The following is a description of a gene set: species: Homo sapiens The t(8;21)(q22;q22) occurs frequently in acute myelogenous leukaemia and gives rise to the transcription factor fusion protein, RUNX1-RUNX1T1 (also known as AML1-ETO). To identify the genes dysregulated by the aberrant transcriptional activity of RUNX1-RUNX1T1, we used microarrays to determine the effect of this mutation on gene expression in human progenitor cells and during subsequent development. Gene signatures of these developmental subsets were very dissimilar indicating that effects of RUNX1-RUNX1T1 are highly context dependent. We focused on gene changes associated with the granulocytic lineage and identified a clinically relevant subset of these by comparison with 235 leukaemia patient transcriptional signatures. We confirmed the overexpression of a number of significant genes (Sox4, IL-17BR, CD200 and gamma-catenin). Further, we show that overexpression of CD200 and gamma-catenin is also associated with the inv(16) abnormality which like RUNX1-RUNX1T1 disrupts core binding factor activity. We investigated the functional significance of CD200 and gamma-catenin overexpression in normal human progenitor cells. The effect of IL17 on growth was also assessed. Individually, none of these changes were sufficient to recapitulate the effects of RUNX1-RUNX1T1 on normal development. These data provide the most comprehensive and pertinent assessment of the effect of RUNX1-RUNX1T1 on gene expression and demonstrate the highly context-dependent effects of this fusion gene. Genes down-regulated in monocytes by RUNX1-RUNX1T1 fusion. Human Gene Set: TONKS_TARGETS_OF_RUNX1_RUNX1T1_FUSION_MONOCYTE_DN from publication Tonks A, Pearn L, Musson M, Gilkes A, Mills KI, Burnett AK, Darley RL (PMID 17898786), and this is the list of marker genes: IVNS1ABP, PTGER3, LTB, ADAMDEC1, CD1C, HBG1, PDE4A, CD1E, LDLRAD4, KAT2B, SLC38A1, HIP1, ARL4C, ADAM8, ITGB7, UGCG, PACC1, ROCK2, AP3S2, CD1B, HDC, HBA1, HBB, CCR6, SMARCA2, STK17B, SRPRA, FGL2, ENTPD1, ICAM3, RNF24, MAP3K2, PLXNC1, NR4A2, IRF4, HNRNPH1, GPR171, RGS2, CLC, CASP8, MDM4, UTRN, HLA-DQB1, GGA2, CYP1B1, GNB5, CPA3, PTPN22, S100B, P2RY14, CD46, GM2A, SDC2, CD1A, BTG2, ST8SIA4